Given this list of marker genes Hras, Mapk14, Ralgds, Mapk11, here is a description of the gene set: This event has been computationally inferred from an event that has been demonstrated in another species.<p>The inference is based on the homology mapping from PANTHER. Briefly, reactions for which all involved PhysicalEntities (in input, output and catalyst) have a mapped orthologue/paralogue (for complexes at least 75% of components must have a mapping) are inferred to the other species. studied in species Mus musculus electronically inferred by orthology from the curated human pathway Reactome Pathway: p38MAPK events part of: Signalling to RAS